Given this list of marker genes UROS, TMPRSS6, PKLR, ABCB7, UMPS, TRNT1, RHD, KLF1, CASK, DOCK11, CDAN1, GLRX5, RACGAP1, GATA1, CDIN1, ATPAF2, NHLRC2, RPS14, RHAG, KIF23, RHCE, G6PD, HBB, here is a description of the gene set: Human Gene Set: HP_ANISOCYTOSIS Anisocytosis studied in species Homo sapiens Abnormally increased variability in the size of erythrocytes.